The following is a description of a gene set: species: Homo sapiens Human Gene Set: WP_CYCLINDEPENDENT_KINASE_46_INHIBITORS_IN_BREAST_CANCER Cyclin-dependent kinase 4/6 inhibitors in breast cancer, and this is the list of marker genes: RPTOR, PIK3CD, PIK3C2A, CCNE1, ESR1, AKT1, AKT3, KRAS, CDKN1A, PIK3C2B, CYP19A1, MAPK1, MAPK3, MTOR, PIK3C2G, PIK3CG, IGF1R, EGFR, INS, CDKN1B, PIK3R4, PIK3R3, PIK3CB, RAF1, PIK3R1, CDK4, ERBB2, CDK6, PIK3R5, HRAS, AKT2, PIK3CA, IRS1, NRAS, PIK3R2, CCND1, CDK2, PIK3R6